The following is a description of a gene set: Human Gene Set: GOBP_PROTEIN_DNA_COMPLEX_ORGANIZATION species: Homo sapiens Any process in which macromolecules aggregate, disaggregate, or are modified, resulting in the formation, disassembly, or alteration of a protein-DNA complex., and this is the list of marker genes: TAF11L12, TAF7, RSF1, CENPC, TSPYL6, RB1, MED26, POLR1E, MED19, ITGB3BP, SETSIP, H4C11, NFE2, MED28, H3C8, H2BC14, TSPY4, H2AC25, H3C10, NAP1L1, H1-8, GTF2B, ARID1A, TAF6, MED22, CHAF1A, CDT1, ATRX, TCF4 (NCBI Gene Id 6925), MED29, ATAD2B, SET, H2BC7, MED21, CHRAC1, NAP1L5, H4C7, DAXX, DMC1, MED24, MED14, TAF2, TAF4B, CENPT, CENPX, MCMDC2, GTF2H5, CENPW, MED1, RAD52, CHD2, TAF9 (TATA-box binding protein associated factor 9), HP1BP3, TAF11L9, CHD1, BAZ1A, TAF1, TSPY2, OIP5, H4C13, BRD2, MED9, TAF3, MED31, POLE3, H1-1, CENPP, RRN3, THRA, MED25, GRWD1, ASF1A, TAF11L3, H3C1, H2AX, HAT1, TAF8, H1-9P, ASF1B (anti-silencing function 1B histone chaperone), H1-6, H1-0 (H1.0 linker histone), H4C1, LIN54, CENPN, SPTY2D1, TAF4, NAP1L2, MED18, MED4, GMNN, CABIN1, SMARCB1, MED27, H4C5, TAF11L4, MED7, TAF11L10, CAND1, H4C2, H3C3, SENP6, H3C12, MACROH2A2, TSPY1, TSPY8, SMARCC2, CENPH, SMARCA4, H1-3, WNT10B, MED10, TAF6L, H4C12, HIRA, SMARCA5, UBN1, TAF11L14, MED6, TSPY9, DNAJC9, H4C6, TAF11, MED30, TSPY3, TSPY10, CENPI, HMGB1, PADI4, BRF2 (NCBI Gene Id 55290), TAF5, TNP1, H2BC4, H3C15, H4C14, SMARCD2, ATAD2, SUPT16H, CDC45, ANP32B, H3-4, CENPK, HMGB2, SMARCD1, MCM2, H3-3B, H2BC13, RAD51, MED15, BAZ2A, NPM1, MCM3AP, TSPYL1, H2BC11, H2AB2, BRF1, NAP1L3, H3C14, GTF2A1, GTF2A2, ARID2, TAF11L13 (NCBI Gene Id 112488747), NASP, TAF12, CENPA, CHAF1B, DLGAP5, SMYD3, H2BC6, CREB1, UBTFL1, HJURP, H3C2, CENPF, TP53, KAT6B, RPL23, RBBP4, TAF1C, KAT6A, SHPRH, H3-3A, TAF11L11, TAF11L2, PSMC6, H4C8, SMARCE1, BDP1, MED17, CENPV, H2BC10, CENPO, MED16, ESR1, H1-4, H2AB1, ZNF827, RAD51C (NCBI Gene Id 5889), NAA60, CENPE, NAP1L4, NAP1L6P, SETD2, MIS12, TSPYL2, H3C11, H4C16, TAF1B (TATA-box binding protein associated factor, RNA polymerase I subunit B), TAF13, MIS18A, H3C7, H2BC3, SMARCD3, H3C6, H4C3, TAF11L7, H4C15, MED8, TAF11L8, H4C4, MACROH2A1, H3C4, MED20, MYC, SMARCC1, TRAPPC12, SART3, H2BC17, SSRP1, TERF1, H2BC1, H2BC9, TAF7L, H3C13, KNTC1, H1-5, H2AB3, HEY2, PIAS1, TSPYL5, TSPYL4, NFKBIZ, MED23, TBP, H2BC8, SUPT6H, H2BC21, DR1, HMBOX1, RNF4, TAF10, H2BC15, H4C9, TAF1L, H1-2, SUGT1, MED11, SOX9, POGZ, UBTFL6, H1-10, TAF11L6, UBTF, HMGA1